Given this list of marker genes CCR7, TREM2, CCL19, FAM3D, NOD2, SLC11A1, CCL21, NOD1, CD74, PYCARD, here is a description of the gene set: Any process that activates or increases the frequency, rate, or extent of antigen processing and presentation. Human Gene Set: GOBP_POSITIVE_REGULATION_OF_ANTIGEN_PROCESSING_AND_PRESENTATION species: Homo sapiens